Given this list of marker genes DNAJB6, YWHAQ, GNB1, KLF9, CELF1, RELA, BTG1, PLS3, PREP, BASP1, ATP2B4, HBD, SLC7A5, BHLHE40, ETF1, MORF4L2, RELB, IFNGR2, NFKB2, HNRNPA3, MAEA, BAIAP2, TRIOBP (NCBI Gene Id 23712), EIF1, ARF6, TNK2, ATF3, DDX17, TRAF1, ACTN1, here is a description of the gene set: When normal cells come under stress, the wild-type (WT) p53 level increases resulting in the regulation of gene expression responsible for growth arrest or apoptosis. Here we show that elevated levels of WT p53 or its homologue, p73, inhibit expression of a number of cell cycle regulatory and growth promoting genes. Our analysis also identified a group of genes whose expression is differentially regulated by WT p53 and p73. We have infected p53-null H1299 human lung carcinoma cells with recombinant adenoviruses expressing WT p53, p73 or beta-galactosidase, and have undertaken microarray hybridization analyses to identify genes whose expression profile is altered by p53 or p73. Quantitative real-time PCR verified the repression of E2F-5, centromere protein A and E, minichromosome maintenance proteins (MCM)-2, -3, -5, -6 and -7 and human CDC25B after p53 expression. 5-Fluorouracil treatment of colon carcinoma HCT116 cells expressing WT p53 results in a reduction of the cyclin B2 protein level suggesting that DNA damage may indeed cause repression of these genes. Transient transcriptional assays verified that WT p53 repressed promoters of a number of these genes. Interestingly, a gain-of-function p53 mutant instead upregulated a number of these promoters in transient transfection. Using promoter deletion mutants of MCM-7 we have found that WT p53-mediated repression needs a minimal promoter that contains a single E2F site and surrounding sequences. However, a single E2F site cannot be significantly repressed by WT p53. Many of the genes identified are also repressed by p21. Thus, our work shows that WT p53 and p73 repress a number of growth-related genes and that in many instances this repression may be through the induction of p21. from publication Scian MJ, Carchman EH, Mohanraj L, Stagliano KE, Anderson MA, Deb D, Crane BM, Kiyono T, Windle B, Deb SP, Deb S (PMID 17982488) Human Gene Set: SCIAN_INVERSED_TARGETS_OF_TP53_AND_TP73_DN Genes that were inversely correlated in H1299 cells (lung cancer): down-regulated by P53 and up-regulated by P73. studied in species Homo sapiens